The following is a description of a gene set: Reticular hyperpigmentation Human Gene Set: HP_RETICULAR_HYPERPIGMENTATION Increased pigmentation of the skin with a netlike (reticular) pattern. studied in species Homo sapiens, and this is the list of marker genes: TERT, TP53, NOP10, POLA1, KRT14, USB1, RPA1, NHP2, MPV17, PORCN, TERC, POFUT1, TINF2